Given this list of marker genes CCDC65, RFX5, RAG2, DBH, CLPB, TTC12, PLCG2, DNAAF3, CIITA, CDSN, BRWD1, MCIDAS, SDCCAG8, BBS10, BBS4, BBS5 (NCBI Gene Id 428), HYDIN, CEP290, ODAD2, PGM3, DNAL1 (NCBI Gene Id 83544), BBS7, TRIM32, DNAH9, RSPH3, ZMYND10, DNAAF4, NME8, CLCN7, DNAAF2, RFXANK, RPGR, SLC27A4, CCNO, DNAAF5 (dynein axonemal assembly factor 5), IFT27, CCDC40, BBS12, TNFSF11, SNX10, SIK3, ZNF699, IFT74, CFAP418, ALG12, NLRP1, SPINK5, DNAI2, ODAD3, ARL6, BLM, STK36, DNAH1, FOXJ1, MKKS, ODAD1, DNAH5 (dynein axonemal heavy chain 5), CFAP300, WDPCP, SLC29A3, IGKC, SPAG1, LRRC56, CCDC39, CPN1, IFT172 (intraflagellar transport 172), BBS2, DOCK8, GAS2L2, EDARADD, GFI1, KRT74, SASH3, EDA, BBIP1, SPEF2, TTC8, RSPH9, DNAH11, NEK10, NPHP1, IGHG2, DNAI1, DRC1, RAG1, TAP2, DNAAF6, BBS9, BBS1, RSPH1, DNAAF11, LZTFL1, CCDC103, CARMIL2, ELANE, GAS8, SRP19, DNAJB13, OFD1, CEP19, CFAP74, CFAP298, SCLT1, COX4I2, CFAP221, ODAD4, SCAPER, IDUA, DNAAF1, RFXAP, NME5, RSPH4A, MKS1, TCIRG1, here is a description of the gene set: Rhinitis Inflammation of the nasal mucosa with nasal congestion. species: Homo sapiens Human Gene Set: HP_RHINITIS